The following is a description of a gene set: Human Gene Set: AAGGGAT_MIR188 studied in species Homo sapiens Genes having at least one occurence of the motif AAGGGAT in their 3' untranslated region. The motif represents putative target (that is, seed match) of human mature miRNA hsa-miR-188 (v7.1 miRBase)., and this is the list of marker genes: LUZP1, USP28, CPNE8, SOX4, IGF2BP2, EPC2, SPRED1, TRIP12, TRIAP1, FBXO11, FBXW7, RNF185, MAPK8IP2, TMEM39A, ZFP91, SLC12A2, KPNA3 (NCBI Gene Id 3839), CRKL, KLF12, DLG5, ILF3, RICTOR, EIF4A1, EFNB2, BCL9, MAFB, ENOX2 (ecto-NOX disulfide-thiol exchanger 2), EPHA4, CCNT2, SRSF7, CDC25B, ATXN1, LPAR1, BCL11B, SNN, UBE2I (ubiquitin conjugating enzyme E2 I), PHACTR2, P4HB, H3-3B, FNIP1, RAB14, DENND5A, SLITRK4, MEF2C, PDIK1L, KITLG, DEDD, RAP2C, MAP3K3, RREB1, IL13RA1, LSM12, ELOVL6, NBEA, RNF111, PCDH9 (NCBI Gene Id 57123), PHF3, TMEM30A, ZBTB44 (NCBI Gene Id 29068), AP1S3, SELENOT, CNIH1, MBNL1, NSD2, FAM117B, ACACA, RSPO3, ESR1 (estrogen receptor 1), CHRD (NCBI Gene Id 96177), PTEN, TOMM70, PDE4A, CGN, CXXC5, ZNF281